Given this list of marker genes Slc16a10, Gata3, Med1, Cpq, Tg, Tpo, Slc5a5, Foxe1, Duoxa1, Duoxa2, Ctsk, Slc26a7, Ctns, Slc16a2, Hpn, Ctsl, Pax8, Cga, Slco1c1, Ctsb, Dio2, here is a description of the gene set: Mouse Gene Set: GOBP_THYROID_HORMONE_GENERATION The formation of either of the compounds secreted by the thyroid gland, mainly thyroxine and triiodothyronine. This is achieved by the iodination and joining of tyrosine molecules to form the precursor thyroglobin, proteolysis of this precursor gives rise to the thyroid hormones. studied in species Mus musculus